Given this list of marker genes Kmt2a (lysine (K)-specific methyltransferase 2A), Hnrnpu, Dyrk1a, Setd5, Rlf, Setd1a, L3mbtl3, Kat5, Baz1a, Kdm1a, Mki67, Phf8 (PHD finger protein 8), Cdk2, Tpr, Tlk2, Tal1, Pax7, Ssrp1, Lsm11, Mllt3, Epc1, Samd1, Tlk1, Ing3, Phf2, Dnmt3l, here is a description of the gene set: species: Mus musculus Any process that modulates the frequency, rate or extent of chromatin organization. Mouse Gene Set: GOBP_REGULATION_OF_CHROMATIN_ORGANIZATION